The following is a description of a gene set: Signaling by WNT in cancer Human Gene Set: REACTOME_SIGNALING_BY_WNT_IN_CANCER species: Homo sapiens, and this is the list of marker genes: AMER1, PPP2CA, PORCN, PPP2CB, RNF43, CTNNB1, DKK4, KREMEN2, CSNK1A1, KREMEN1, DKK1, CTBP1, GSK3B, PPP2R1B, FZD6, FZD5, PPP2R5D, CTBP2 (C-terminal binding protein 2), AXIN1, APC, PPP2R1A, LRP6, TNKS2, DKK2 (NCBI Gene Id 27123), FZD8, PPP2R5E, LRP5, PPP2R5C, TCF7L2, PPP2R5A, TNKS, PPP2R5B, WNT3A, FZD4